Given this list of marker genes Slc25a24, Slc25a17, Abcc4, Lrrc8a, Slc25a23, Slc25a42, Slc25a53, Slc25a25, Slc35b1, Slc25a51, Ank, Panx1, Slc25a31, Slc25a5, Slc25a47, Abcc5, Slc25a54, Slc25a41 (NCBI Gene Id 103775), Slc35b2, Slc17a9, Slc46a2 (NCBI Gene Id 80480), Slc25a4, Slc19a1, Slc35b3, here is a description of the gene set: studied in species Mus musculus Mouse Gene Set: GOMF_PURINE_NUCLEOTIDE_TRANSMEMBRANE_TRANSPORTER_ACTIVITY Enables the transfer of a purine nucleotide, any compound consisting of a purine nucleoside esterified with (ortho)phosphate, from one side of a membrane to the other.